Given this list of marker genes RTN4, KDM1A, PAFAH1B1, FAIM, MEF2C, AGRN, DLL1, MECP2, DISC1, MAP1B, NEUROD1, IL17A, PAX6, MAPT, TCF4, MRE11, NTRK2 (neurotrophic receptor tyrosine kinase 2), JAG1, NTRK3, CDK5R1, NEUROG3, NDEL1, PLXND1, NUMBL, ID1, NGF (NCBI Gene Id 4803), RELN, PSEN1, NUMB, ASCL1, GHRL, MARK2, CXCL12, SEMA4A, APP, NGFR, MYC, TCF3, HEY1, MAP2, ERBB4, HES1, LRP8, RTN4R, NTRK1, RET, GSK3B, DAB1, VLDLR, CDK5, NRG1, NOTCH1, BDNF, ID2, SOX2, NEURL1, STAT3, here is a description of the gene set: Neurogenesis regulation in the olfactory epithelium Human Gene Set: WP_NEUROGENESIS_REGULATION_IN_THE_OLFACTORY_EPITHELIUM species: Homo sapiens